Given this list of marker genes ACCS, SLC15A1, PIEZO1, SHFL, A2M, PEX11A, SYNJ2BP, ACBD4, LTBP4, SERPINA5, RGS2, MYO10, SCNN1D, CNNM3 (NCBI Gene Id 54786), SLC19A3, MT1A, CXXC1, SLC25A37, MYO7A, TNFAIP8L1, ASPDH, RCN1, MAP2K7, ANPEP, PAQR7, CERS4, WDR72, C9, NAT2, ERLIN1, TNFRSF21, CROT, FGL1, SLC22A1, KIAA2013, VAMP8, RAP1GAP, TBPL1, ZBTB48, ATP6V1B2, DCPS, CHPF, MT2A, TCIM, ENTPD5, DGAT2, IER3, CPED1, AIG1 (androgen induced 1), PRNP, CFLAR, HADHA, NR0B2, MT1X, VPS37B, CHMP7, PROZ, FAM99A, GPD1, MT1G, THRSP, CSRNP1, CCND1, STAB2, ACP2 (NCBI Gene Id 96117), PNPLA7, SPP2, TRIP6, SEC14L1, LECT2, NSMF, SLC7A5, RDH11, PLIN2, ATF5, MAN2B2, CHST4, VIPR1, GSDMB, ETS2, TRIB1, SLC25A47, HAMP, PHKA2 (phosphorylase kinase regulatory subunit alpha 2), LIPG, TRPM8, SELENOW, PNMA6A, INMT, PGGHG, PON1, AXL, MT1P3, IGFALS, DNASE1L3, TENT5A, MYOM2, RELN, CTSD, HOOK1, OCIAD1, CDH2, CCAR1, MT1F (metallothionein 1F), EZR, MBD3, TMEM86B, CYFIP2, RAB33B, AGMAT, EGR1, INHBE, KRCC1 (NCBI Gene Id 51315), IGFBP3 (NCBI Gene Id 3486), BGN, PLG, PINK1, PCNX1, MFN2, RGL1, SERTAD1, NRDE2, MYCBP2, B4GALT4, MINDY3, ATG14, ARHGAP10, PLEKHG3, C11orf24, DEFB1, IRF8, ABCB7, ZSWIM8, HSBP1, LRRC75B, MAGT1, RAB17, GSDME, STAB1, AVPI1, IDO2, NOP14, HMGCL, HDAC6, MTTP (microsomal triglyceride transfer protein), FOSB, CLUH, PLXNB1, TKFC, SKAP1, CD68, GADD45G, AQP12A, ACADVL, MT1M, FCN3, PPIG, SPIRE1, NOCT, JAML, GLUD1 (glutamate dehydrogenase 1), HOGA1, PNMA3, ARMC6, GCKR, BBOX1, PROC, ATOH8, JUND, DUSP5, EVC2, COLEC11, MXRA5 (NCBI Gene Id 91006), CYP1A2, ACOX3, PMPCA, CYP3A5, PDSS2, PVR, FTCD, RBM25, F9, EPHX2, PCMT1, SYMPK, ZNF593, IGF2, FBP1, C2orf42, TCF25, HGFAC, CYP2C9, ARG1, ADRA1B, KLKB1, TNPO3 (transportin 3), ANGPTL8, TMEM30B, CFAP410, CYP2E1, SH3YL1, AKR7A3, C3, AFM, NR4A2, OGDHL, C1RL, PEX3, ADAMTSL2, MFAP4, PHGDH, BHLHE40, SH3TC1, LRRFIP1, EPHA2, AZGP1, ENO3, SARAF, INTS6, PPP1R15A, NUCKS1, FHIP1B, MLXIPL, HDHD2, LY6E, EIF2S1, C7, KAT6A, DLST, SPINT2, SAA4, RAB3IL1, ITIH3, CHST7, VKORC1, RAB26, ANKRD33, PPARGC1A, MACROD1, SHBG, CYP3A7, ECHS1, GHR, CDA, FAHD2B, TERF2IP, MFSD2A, FAAH, NDRG2, F12, SETDB2, CDHR2, ZNF395, ASB1, DEPP1, SNORC (NCBI Gene Id 389084), LCAT, DPT, ACADS, ACAA1, GRAMD2B, VNN1, DCUN1D3, FRG1, ZNF148, FOS, ALDOB, GCGR, PTH1R, MARCHF6, LYRM1, SPTBN5, SH2D4A, DENND4C, here is a description of the gene set: Human Gene Set: ACEVEDO_LIVER_TUMOR_VS_NORMAL_ADJACENT_TISSUE_DN from publication Acevedo LG, Bieda M, Green R, Farnham PJ (PMID 18413731) Genes down-regulated in liver tumor compared to the normal adjacent tissue. There is widespread interest in efficient characterization of differences between tumor and normal samples. Here, we show an effective methodology for genome-scale characterization of tumors. Using matched normal and tumor samples from liver cancer patients, as well as non-cancer-related normal liver tissue, we first determined changes in gene expression as monitored on RNA expression arrays. We identified several hundred mRNAs that were consistently changed in the tumor samples. To characterize the mechanisms responsible for creation of the tumor-specific transcriptome, we performed chromatin immunoprecipitation on microarray experiments to assay binding of RNA polymerase II, H3me3K27, and H3me3K9 and DNA methylation in 25,000 promoter regions. These experiments identified changes in active and silenced regions of the genome in the tumor cells. Finally, we used a virtual comparative genomic hybridization method to identify copy number alterations in the tumor samples. Through comparison of RNA polymerase II binding, chromatin structure, DNA methylation, and copy number changes, we suggest that the major contributor to creation of the liver tumor transcriptome was changes in gene copy number. studied in species Homo sapiens